Given this list of marker genes MYG1, MRPL40, CSRNP3, SPINK13, QRSL1, CEBPG, OTOA, RIPK2, EIF2B4, SLC33A1, B4GALT4, ATP1B1, CFLAR, NDUFAF3, SMAD4 (SMAD family member 4), CASTOR2, TMEM30A (NCBI Gene Id 55754), OSCAR, BST2, GNA15, SYNE2, CRELD2, ZSCAN29, PLEKHG5, IQGAP2, ATF1, BMPR2, RAB33B, WDCP, HDAC9, GPR146, CARHSP1, FGFBP1 (fibroblast growth factor binding protein 1), DHX16, FAM8A1, PIK3R5, SRGAP3, INPP4A, OAS2, SAP18, CCNA2, JMJD1C, RAPH1, NEDD4L, AMBP, SERP1, DDHD1, KLHL2, GTPBP4 (GTP binding protein 4), NUDT16, RTCA, FMNL2, INSIG2, SETBP1, ATP6V0A1, PLXNC1, TCF7, FMR1NB, NCKAP1, TCP11L2, KIF4B, SNX25 (NCBI Gene Id 83891), CYP51A1, PLEKHM3 (NCBI Gene Id 389072), RAB9B, LETM2, KCNE3, NFIL3, CDH9, PPP1CC, SLC6A4, TICAM2, SDCBP2, SLPI, CDC42EP3, ZKSCAN5, ULK2 (NCBI Gene Id 9706), FBXO8, PRSS58, APPL2, RUNX2, CARD6, SIKE1, S100A6, MIR10B, ENOX2, HAMP, PRKAB2, POLR2H, CDH12, SNX5, ABCA6, ANO10, TTF1 (NCBI Gene Id 7270), CEP135, LGR5, CAV2, SIN3B, PACSIN1, ARHGAP17, GAB2 (NCBI Gene Id 9846), CRY1, TRIM32 (NCBI Gene Id 3971), TUT7, TMCC1, RABIF, MIOX, SCN11A, PRG2, PTPN6 (NCBI Gene Id 5777), MSMO1, RNF41, IDS (iduronate 2-sulfatase), ANKRA2, HCN2, AP1M2 (adaptor related protein complex 1 subunit mu 2), TMED10, TENT4B, TEX13A, F8A1, IL2RA, NDUFAB1, PRR3, MRI1 (NCBI Gene Id 84245), NUDT19, GATC, MAPK7, LMAN2, STXBP2, CYFIP1, FAM114A2, PTPRJ, LPP, CYP20A1, DNAJC28, HACE1, PPP4R2, FAM193A, ARID4A, SST, UBTD1, DNTTIP1, FNTA, PCOLCE, SGO2, TBC1D8, LIFR, GPR155, NCOA1, LITAF, ARPC3, BHLHA15, RASSF8, APC, AIDA, ZFYVE19, CCDC77, CTSA, HEXB, here is a description of the gene set: Genes up-regulated in NK cells versus CD8 T cells. species: Homo sapiens Murine Cytomegalovirus (MCMV) infection leads to early activation of various immune cells, including B and T lymphocytes, before the actual initiation of antigen-specific adaptive immunity. This activation is partly driven by innate cytokines, including type I interferon (IFN), which are induced early after infection. The objective of this study was to address the role of type I IFN in shaping early/innate B and T cell responses to a primary acute viral infection. In order to decipher the specific impact of IFN-I on cell subsets, we performed a genome-wide expression analysis on WT splenic B and CD8 T lymphocytes isolated from C57BL/6 mixed bone marrow chimera mice. This study complements series GSE39555, which focused on early responses of NK cells and of the two subsets of conventional dendritic cells. Human Gene Set: GSE45365_NK_CELL_VS_CD8_TCELL_UP